Given this list of marker genes VNN3P, CCN2, AGPAT2, QSOX1, PLD1, HPS5, IER3, RAB27A, F2RL1, BHLHE40, TRIB1, NAV2, LGALS3BP, MAFF, THBS2, IL4R, NCALD, here is a description of the gene set: Hepatocellular carcinomas (HCCs) are a heterogeneous group of tumors that differ in risk factors and genetic alterations. We further investigated transcriptome-genotype-phenotype correlations in HCC. Global transcriptome analyses were performed on 57 HCCs and 3 hepatocellular adenomas and validated by quantitative RT-PCR using 63 additional HCCs. We determined loss of heterozygosity, gene mutations, promoter methylation of CDH1 and CDKN2A, and HBV DNA copy number for each tumor. Unsupervised transcriptome analysis identified 6 robust subgroups of HCC (G1-G6) associated with clinical and genetic characteristics. G1 tumors were associated with low copy number of HBV and overexpression of genes expressed in fetal liver and controlled by parental imprinting. G2 included HCCs infected with a high copy number of HBV and mutations in PIK3CA and TP53. In these first groups, we detected specific activation of the AKT pathway. G3 tumors were typified by mutation of TP53 and overexpression of genes controlling the cell cycle. G4 was a heterogeneous subgroup of tumors including TCF1-mutated hepatocellular adenomas and carcinomas. G5 and G6 were strongly related to beta-catenin mutations that lead to Wnt pathway activation; in particular, G6 tumors were characterized by satellite nodules, higher activation of the Wnt pathway, and E-cadherin underexpression. CONCLUSION: These results have furthered our understanding of the genetic diversity of human HCC and have provided specific identifiers for classifying tumors. In addition, our classification has potential therapeutic implications because 50% of the tumors were related to WNT or AKT pathway activation, which potentially could be targeted by specific inhibiting therapies. species: Homo sapiens Down-regulated genes in hepatocellular carcinoma (HCC) subclass G56, defined by unsupervised clustering. from publication Boyault S, Rickman DS, de Reyniès A, Balabaud C, Rebouissou S, Jeannot E, Hérault A, Saric J, Belghiti J, Franco D, Bioulac-Sage P, Laurent-Puig P, Zucman-Rossi J (PMID 17187432) Human Gene Set: BOYAULT_LIVER_CANCER_SUBCLASS_G56_DN